Given this list of marker genes Psmc5 (protease (prosome, macropain) 26S subunit, ATPase 5), Usp8, Cdk5, Oprl1, Abhd6, Cacna1d, Musk, Gls, Chrnd, Rasd2, Ptchd1, Arid1b, Rapsn, Mir487b, Ghrl, Usp46, Ptgs2, Snapin, Dbn1, Chrna9, Afdn, Cc2d1a, Ntsr1, Mir218-2, Gnal, Zmynd8, Gabra4, Elfn1, Apba3, Mir28a, Lypd1, Syp, Mir667, Lrp8, Nrxn2, Sct, Hrh1, Kcnj10, Sncaip, Mir181b-1, Ccl2, Grin3a, Slc12a4, Lamp5, Ppfia3, Epha7, Mir153, Syde1, Lnpep, Ntrk1, Htr3a, Ncs1, Pfn2, Slc1a1, Mir150, Nedd4, Prkar2b, Epha4, Grin2d, Syn2, Penk, Rac1, Fbxo2, Chrnb2, Hcrt, Clstn1, Ston2, Cadps2, Grik4, Mir30d, Mir383, Dagla, Mirlet7e, Lrrc4, Sptbn2 (spectrin beta, non-erythrocytic 2), Vps13a, Zdhhc3, Synpo, Shc3, Sv2a, Gria1 (NCBI Gene Id 72995), Cspg5, Rimbp3, Igsf21, Unc13a, Kctd13, Chrnb3, Dlgap2 (NCBI Gene Id 244310), Vamp2, Pcdh17, Stxbp3, Slc38a1, Slc12a2, Mirlet7c-1, Chrm5, Npff, P2rx2, Mir9-1, Nr3c1, Slc5a7, Arhgap44, Ager, Rph3al, Slc17a8, Nr2e1, Mef2c, Tmem25 (transmembrane protein 25), Cnrip1, Clstn2, Drp2, Mir26b, Unc13c, Sqstm1, Rasgrf2, Mir134, Syn1, Eif4a3, Mir467b, Cyp46a1, Serpine2, Ctbp2, Slc24a1, Slitrk5, Glra4, Kcnc4, Nmu, Wnk1, Fchsd2, Mir338, Creb1, Kiss1r, 2610042L04Rik, Chrna1, Chat, Mir320, Hrh4, Cacnb4, Mir379 (microRNA 379), Nfatc4, Kif5b, Dlg4, Mir181a-2, Retn, Ncstn, Ckap5, P2rx3, Abcc8, Eif4e, Il1b, Syngr3, Mir128-1, Egr2, Lrp6, Rnf167, Mir100 (microRNA 100), Tprg1l, Insyn2a, Fabp5, Rims2, Mir187, Npy (NCBI Gene Id 68398), Camk2a, Mir9-3, Erbb4, Adipoq, Mir467a-6, Plcb4, Rgs14, Snap25, Mapk8ip2, Hrh2, Mir421, Rab3gap1, Fbxo41, Rapgef4, Cntn2, Chrna7, Stx19, Spg11, Syt4, Mir138-2 (NCBI Gene Id 723956), Gabrg1, Cacng2, Gdnf, Akap7, Ywhah, Mir92-1, Rims4, Mir19b-2, Vps54, Pafah1b1, Nalcn, Tnr, Slc7a11, Stat3, Stxbp5, Trpv1, Cdh1, Ly6i, Cdkl5, Mir23a, Gfap, Atp2b2, Slc18a3, Trim9, Cckbr, Vdac1, Mir29a, Anxa7, Ntng1, Ggcx, Egfr, Stx2, Ly6a, Syngap1, Map1a (NCBI Gene Id 99114), Sybu, Ptk2b, Igsf9b, Igsf11, Ptprs, Mir92-2, Grk2, Bche, Celf4, Edn3, Lin7a, Tpgs1, Prkce, Stx1a, Shisa9, Ube3a, Mapk3, Cacna1c, Grid2, Jph4 (junctophilin 4), Tpbg, Dvl1, Mir181a-1, Ly6g6d, Slc7a10, Nrg3, Exoc4, Atxn1, Prkn, Celf6, Vamp1, Mir540, Npr2, Kit, Rgs4, Chrna10, Chrna5, Htr5b, Stx3, Crhr2, Rnf10, Camk2d (NCBI Gene Id 77170), Chrna4, Hnrnpk, Prkcg (NCBI Gene Id 18752), Grm1, Drd1 (NCBI Gene Id 77537), Plg, Cacna1e, Mir673, Ythdf1, Chrdl1, Mir672, Mirlet7c-2, Grm6, Dlgap4 (NCBI Gene Id 98882), Gper1, Park7, Mir467a-9 (microRNA 467a-9), Adcy1 (adenylate cyclase 1), Ly6g6e, Wnt7a, Synpr, Slc38a2, Rap1b, Tmem108, Ccr2, Nlgn3, Kcnd3, S100b, Ly6g6g (lymphocyte antigen 6 family member  G6G), Mir20a, Iqsec2, Tac1, Eif2ak4, Abl1, Syt13, Bglap, Gria4, Eif4ebp2, Snap23, Rapgef2, Gnao1, Nrg1, Bcl2l1, Atg5, Kmt2a, Gjc1, Htr2b, Mir181d, Mir98, Sncg, Cdk5r1, Gabbr1, Plcb1, Il1rap, Mir433, Lrrtm1, Grid2ip, Ncan, Plcg1, Stau2, Cnih3, Mir126a, Ly6c2, Egr1, Chrm2, Cd24a, Mirlet7f-2, Ptprd, Cbln4, Gnai1, Neo1, Adrb2, Npy1r, Cacnb1, Snap47, Synj1, Pclo, Tbc1d24, Npy2r, Gabre, Asic1, Drd2, Lrrk2, Aph1c, Ly6g, Gabra5, Mir26a-1, Cplx3, Crhbp, Bglap2, Neto1, Zdhhc2, Nlgn1, Rab3gap2, Begain, Snca, Mir30c-2, Glul, Htr5a, Ly6h, Fbxl20, Gprin3, Otof, Baiap2, Adora2a, Hap1, Zdhhc17, Mir467a-7, Rab5a, Mir211, Stxbp5l, Btbd9, Kcnb1, Cnih2, Mir324, Grip1, Ctnnd2, Best1, Osbpl2, Ina, Camk2g, Slc6a6, Slitrk4, Mir128-2, Trio, Adnp, Sncb, Nog, Cdh8, Mirlet7f-1, Mir30e, Grm2, Prr7, Pirb, Tmod2, Dgkb, Cck, Erc2, Slc24a2, Ly6m, Kcnj8, Ctnnb1, Cdh2 (cadherin 2), Mir872, Syt2, Pla2g6, Lin7c, Slc6a9, Vps18, Myo6 (NCBI Gene Id 60360), Igf1r (NCBI Gene Id 77773), Stx4a, Septin5, Mylk2 (myosin, light polypeptide kinase 2, skeletal muscle), Dtnbp1, Pdlim4, Slc12a6, Pdyn, Gabra6, Mctp2, Fgf22, Cntnap4, Camk2b, Rims3, Prepl, Mir7b, Gip, Nrxn1, Mir124a-1hg, Scrib, Agt, Mir129-1, Rac3, Adra2a, Nlgn2, Slc12a5, Grik5, Slc6a2, Dag1, Mirlet7d, Mir181c, Cntnap2, Mir29b-2 (microRNA 29b-2), Rab3b, Fchsd1, Mir411, Gsg1l, S1pr2, Gucy1a1, Efnb3, Th, Drd5, Ppp3r1, Chrnb4, Prkca, Gnaq, Nlgn4l, Htr4, Adarb1, Mir17, Ghsr, Cx3cr1, Pde4a, Prkcb, Cacna1b, Mir129-2, Mir149, Mir484, Jph3, Lama2, Mir145a, Mir551b, Dnm1, Car2, Dbi, Mir300, Mir9-2 (microRNA 9-2), Hras, Ucn, App, Mtor, Tsc2, Ezh2, Grik3, Nps, Mmp9, Cpeb2, Vgf, F2r, Tnf, Atp2a2 (ATPase, Ca++ transporting, cardiac muscle, slow twitch 2), Nrn1, Dgke, Slc1a7, Rnf216, Mir181b-2, Chmp2b, Mir22, Mir24-1, Ly6g2, Gpr151, Fam107a, Kcnc3, Mgll, Gjd2, Gabrg2 (gamma-aminobutyric acid type A receptor, subunit gamma 2), Tyrobp, Kcnh1, Arf1, Kpna1, Git1, Nat8l, Neurl1a, Ywhag, Ppp1r9a, Plat, Adcy8, Akap5, Cdc20, Pink1, Notch1, Mir125a, Shisa7, Cep89, Bcr, Cacna1g, Gnai2, Abr, Htr6, Syt8, Mir151, Mir204, Atf4 (activating transcription factor 4), Shank2 (SH3 and multiple ankyrin repeat domains 2), Map1b, Kat2a, Grid1, Glra2, Oprm1, Cux2, Clstn3, Mir137, Enpp1, Mir425, Htr3b, Nf1, Cacng4, Syap1, Ptpn5, Mir500, Mir301b, Gabbr2, Camkv, Flot1, Cd2ap, Snap91, Mir29b-1, Grm3, Mir410, Chrna6, Sh3gl1, Bsn, Dgki, Ptpra (NCBI Gene Id 19262), Nptn, Itgb1, Mapk9, Slc4a8, Clcn3, Rph3a, Kras, Mdm2, Htr1b, Faah, Mir674, Dtna, Aph1b, Mir744, Utrn, Mir127, Rims1, Htr1d, Rgs8, Mpp2, Gria3, Syt1, Mir369, Mycbpap, Adora1, Mir30c-1, Disc1, Nrxn3, Npas4, Cyth1, Pnoc, Nppa, Gabra1, Syngr1 (NCBI Gene Id 98000), Myo5b, Napb, Gpr158, Kmo, Wnt3a, Stac3, Fgf14, Calhm2, Chrna3, Cfl1, Brsk1, Clmp, Dlg2, Ly6c1, Cpeb1, Gabrg3, Nisch, Crh, Micu3, Slc17a7, Orai1, Cacng5, Sphk1, Kif1b, Alg13, Plcl1, Gabra2, Itpr1, Syt11, Cabp1, Htr2a, Anxa9 (annexin A9), Lrfn2, Rps6kb1, Usp14, Ly6f, Grm4, Prnp, Fbxo45, Cd38, Grik1, Homer1 (homer scaffolding protein 1, NCBI Gene Id 26556), Atad1, Cacna2d2, Cacng8, Dnm1l, Rhot1, Mir19b-1, Adora2b, Mir467a-5, Grm8, Rgs10, Itpka, Unc13b, Pate6, Mir195a, Lgmn, Tent2, Akap12, Grin2b, Ly6e, Ophn1, Mir125b-1, Chrne, Chrm3, Lrit1, Ppfia2, Pick1, Itpr3, Ntf5, Mir330, Psen2, Apoe, Mir7-2, Mir342, Ptn, Gabra3, Ica1, Lrit3, Chrm1, Prkar1b, Mir337, Mir760, Eif4a3l2, Mtmr2, Cartpt, Mapk1, Pfn1, P2rx6, Sorbs1, Mir191, Prkar2a, Htt, Dmxl2, Mctp1, Ncdn, Mme, Acp4, Rara, Htr1a, Lgi1, Ptprn2, Rasgrf1, Ngdn, Ache, Syn3, Nos1, Mir467a-3, Syt7, Ifng, Doc2a, Camk4, Star, Grik2, Frrs1l (NCBI Gene Id 230235), Dkk1, Slc1a3, Kcnma1 (NCBI Gene Id 70528), Car7, Slc4a10, Cdh11, Lrrtm2, Lrrc4c, Srf, Sez6, Grin2a, Eea1, Mir328, Mir467a-4, Sorcs2, Syt3, Tspoap1, Mir19a, Cacng3, Drd3, Mir92b (NCBI Gene Id 100124470), Dmpk, Pvalb (NCBI Gene Id 19293), Ntng2, Ext1, Sorbs2 (NCBI Gene Id 77324), Mir106b, Syt6, Mir539, Mir222, Gna11, Hip1, Sv2c, Elfn2 (leucine rich repeat and fibronectin type III, extracellular 2), Mir30b, Htr1f, Fyn, Adra1a, Chrm4, Mir15a, Pmch, Nsmf, Anapc2, Cav2, Nrgn, Dytn, Sipa1l1, Lypd6, Mir124-2hg, Hnmt, Slc30a1, Cacnb3, Ror2, Rab11a, Gria2, Dscam (NCBI Gene Id 78761), Stxbp2, Gabrb2, Adrb1 (NCBI Gene Id 11554), Hapln4, Slc12a7, Cacnb2, Nxph1, Shank1, Gsk3b, Pate4, Erc1, Tacr1, Mir467a-2, Adora3, Pdzd11, Cln3, Neurod2, Psen1, Apba2, Uts2, Prrt1, Ssh1, Cplx2, Mirlet7i, Nr3c2, Shisa6, Slc8a3, Kcnq2, Syt12, Glra1, Dlgap3, Kpna2, Ace, Hdac6, Sorcs3, Mir501, Grm7, Prkaca, Mir125b-2, P2ry2, Snx14, L1cam, Chrng, Rab3a, Nsg1, Tubb2b, Nefl, Cask, Zdhhc12, Rap1a, Slc6a1, Il1rapl1, Cplx4, Ptger4, Pten, Cbln1, Oxtr, 2510002D24Rik, Mir541, Kcmf1, Slc8a2, Neto2, Gabrb3, Reln, Fxr2, Dlgap1, Sv2b, Wnt5a, P2ry4, P2rx4, Cpeb3, Mir7-1, Mir25, Ephb1, Mir467a-8, Stim1, Vps35, Htr2c, Rab8a, Kcnn2, Mir770, Pcdh8, Hrh3, Glrb, Igf1, Mir101a, Abi1, Mir467a-10, Cadps, Syt10, Slc17a6, Cyfip1, Syt5, Rtn4, Mir381 (microRNA 381), Grin1, Eif4a3l1, Crhr1, Doc2b, Grin3b, Kdr, Mir382, Nxph4, Atp1a3, Arc, Kcnk2, Dlg1, Doc2g, Drd4, Git2, Ube2i, Large1, Grm5, Cacna1a, Stau1, Mir101b, Mir221, P2rx1 (NCBI Gene Id 18568), Gipc1, Edn1, Dtnb, Jak2, Plppr4, Mir486 (microRNA 486), Nr4a1, Cacng7, Arrb2 (arrestin, beta 2), Tor1a, Iqsec1, Mink1 (NCBI Gene Id 50932), Igsf8, Psca, Htr7, Lynx1, Plk2, Ntrk2, Prrt2, Mir93, Mir1983, Abat, Glra3, Cadm1, Apba1 (amyloid beta precursor protein binding family A member 1), Gabrd, Als2, Farp1, Grip2, Mir467a-1, Aldh5a1, Mapt, Slc6a4, Shisa8, Mir374b, Cnr1, Syt9, P2rx7, Nefh, Crtc1, Slurp2, Hmgcr, Shank3, Zzef1, Homer3, Tacr2, Myo5a, Ppp3ca, Chrna2, Grin2c, Cplx1, Phf24, Mir384, Kcnip1, Cbln2, Pnkd, Mir130a, Mir148b, Adgrb1, Mir132, Xbp1, Mir345, Fcgr2b, Mir99a, Dcdc2a, Tenm2, Crkl (NCBI Gene Id 68624), Npy5r (neuropeptide Y receptor Y5), Pde9a, Slc29a1, Insyn1, Kcnq4, Fmr1, Mir652, Dmd, P2ry1, Trpc1, Ncam1, Efr3a, Cx3cl1, Ptk2, Calb1, Ephb2, Vdac3, Bace1, Mir23b, Adcyap1, Mecp2 (NCBI Gene Id 338503), Abtb3, Tshz3, Bdnf, Mir30a, Ngfr (NCBI Gene Id 18053), Rimbp2, Plcl2, Mir26a-2 (NCBI Gene Id 723962), Etv5, Ppt1, Mir434, Gabrr1 (gamma-aminobutyric acid type A receptor subunit rho 1), Lzts1, Egr3 (early growth response 3), Stx11, Ric3, Kiss1, Chrd, Kcnq3, Mir218-1, Prkcz, Pacsin2, Mir24-2, Mir378a, Rela (v-rel reticuloendotheliosis viral oncogene homolog A (avian)), Ngf, Paip2, Cnr2, Mir138-1, Slc6a5, Lin7b, Rnf19a, Dlg3, Slitrk3, Napa, Mir106a, Stx1b, Stxbp1, Mapk8, Pak1, Oxt, Met, Anks1b, Chrnb1, Rin1, Dcc, Snap29, Agrn, Comt, Fgf12, Sctr, Braf, Pxk, Fxr1, Baiap3, Ntf3, here is a description of the gene set: Mouse Gene Set: GOBP_SYNAPTIC_SIGNALING studied in species Mus musculus Cell-cell signaling to, from or within a synapse.